The following is a description of a gene set: The process in which vesicles are directed to specific destination membranes during transport to, from or within the Golgi apparatus; mediated by the addition of specific coat proteins, including COPI and COPII proteins and clathrin, to the membrane during vesicle formation. species: Mus musculus Mouse Gene Set: GOBP_VESICLE_TARGETING_TO_FROM_OR_WITHIN_GOLGI, and this is the list of marker genes: Pdcd6, Sar1b, Trappc1, Cul3, Trappc2l, Tmed9, Trappc12, Ap1ar, Sec16a, Tmed10, Dipk2a, Arfgap2 (ADP-ribosylation factor GTPase activating protein 2), Pef1, Wipi1, Trappc3, Trappc11, Sar1a (NCBI Gene Id 67913), Klhl12, Arfgap3, Preb, Tmed10-ps, Trappc2, Gbf1, Cep19, Trappc6a, Trappc5, Mapk15, Trappc4 (trafficking protein particle complex 4)